The following is a description of a gene set: from publication Chen Y, Wang X (PMID 31504780) Mouse Gene Set: MIR_148B_5P Genes predicted to be targets of miRBase v22 microRNA mmu_miR_148b_5p in miRDB v6.0 with MirTarget v4 prediction scores > 80 (high confidence targets). studied in species Mus musculus, and this is the list of marker genes: Bccip, Prrx1, Nr3c2, Mrps2 (mitochondrial ribosomal protein S2), Fhad1 (NCBI Gene Id 73073), Dclre1a, Hebp1, Zfp383, Fermt1, Tmem154, Mzt1, Fjx1, Ube2ql1, Acp3 (acid phosphatase 3), Galntl6, Adss2, Umps, Cdc73, Nup54, Tent5a, Eva1a, Idh3a, Slit3, Fam13b, Cul2, Rcn2, Ppp4r3b, Sash3 (SAM and SH3 domain containing 3), Canx, Sycp3, Tm9sf2, Tmed7, Hsd3b1, Txn2, Rnf38, Dlst, Tmem68, Tollip, Flrt3, Nup35, Men1, Macroh2a2, Abracl, Ccl22, Rrp36, Stard6, Tet1, Slc30a10, Smad4, Setd6, Arhgef6, Ncoa6, Tmem158, Spata1, Kmt5b, Cfap298, Clca2, Ccdc73, Msi2, Tc2n, Kifc3, Tead1, Hspa5 (heat shock protein 5), Map3k2, Ncoa2, Slc4a4, Wdr11, Hmgcr